The following is a description of a gene set: studied in species Homo sapiens Human Gene Set: GOMF_CYSTEINE_TYPE_ENDOPEPTIDASE_ACTIVITY Catalysis of the hydrolysis of internal, alpha-peptide bonds in a polypeptide chain by a mechanism in which the sulfhydryl group of a cysteine residue at the active center acts as a nucleophile., and this is the list of marker genes: CASP12 (NCBI Gene Id 120329), CASP5, NLRP12 (NCBI Gene Id 91662), CTSK, USP5, CTSO, CAPN7, CSTA, USP12, CTSB, KNG1, CSTL1, RCE1, SENP2, WFDC2, CST3, CASP6, USP1, ADGB, HSPD1, USP14, SNCA, SENP6, CAPN9, HRG, NLRP3, NLRP1, USP33, ATG4D, CAPN3, SENP5, USP6, ATG4A, USP29, CTSF, MALT1, CASP9, ATG4C, SERPINB3, BLMH, CST9, CAPN14, USP13, USP10, USP9X, SENP1, CAPNS1, PTTG1, ATG4B, CTSL, CAPN11, BIRC6, PYCARD, CST1, BIRC7, CASP8, USP27X, GPAA1, BIRC5, CST2, USP37, CAPN1, CAPN5, UCHL1, LGMN (legumain, NCBI Gene Id 5641), APAF1, CSTB, CST5, PDIA3, CTSS, XIAP, USP16, CASP10, TIMM50, AIM2, CST4, CAPN8, CAPNS2, CAPN13, CAPN10, USP7, CAPN6, LCN1, USP8, NAIP, CST7, CTSH, CASP3, CST9LP1, SENP7, USP34, USP20, CASP1, PIGK, USP11, USP48, SERPINB13, SPOCK1, AHSG, ST20, CTSD, CST6, CASP14, CASP7, CARD16 (caspase recruitment domain family member 16), FETUB, ESPL1, CARD8, LTF, PIGU, CFLAR, CTSC, USP15, CST8, CST11, BAD, TINAG, CTSZ, CARD17P, CARD18, USP49, USP2, SFRP1, CASP4, CTSW, USP30, CASP2, CST9L, CAPN12, CAPN2, CTSV, CSN2, CAPN15, CAST